The following is a description of a gene set: Inwardly rectifying G protein activated K+ channels (GIRK) are tetrameric assemblies of Ki3 3 family subunits (Kir 3.1, 3.2 3.3 and 3.4). The activation of G protein coupled receptor by ligand results in the liberation of G alpha and G beta gamma subunits. Gbeta gamma subunits interact and activate GIRK channels. Reactome Pathway: G protein gated Potassium channels studied in species Homo sapiens part of: Inwardly rectifying K+ channels, and this is the list of marker genes: GNB3, GNB4, KCNJ16, GNB1, KCNJ4, KCNJ12, GNGT1, GNB5, KCNJ2, GNGT2 (G protein subunit gamma transducin 2), KCNJ5, GNG7, KCNJ9, GNG12, GNG8, KCNJ3, KCNJ6, KCNJ10, GNG13, GNG5, GNG3, GNG11, GABBR1, GNG4, GNB2, GABBR2, KCNJ15, GNG10, GNG2